Given this list of marker genes RBL1, IKBKE, HIVEP3, LPAR2, SPSB1, DCK, ARID5A, SRSF10, TNKS2, EIF4E, ARHGEF3 (NCBI Gene Id 50650), NEFH, ATF6B, MLLT1, ENTPD4, PRDM2, SH3BP5, HNRNPH3, PTGER4, CHST15, STARD5, MYG1, GATA1, PLEKHA1, AHDC1, RPS26, GTPBP8, WDR77, UBXN11, LTB, SH2B3, TSPAN5, GSAP, PTPN1, CPSF4, KCNIP2, KCNA2, RBM45, RPL4, IDH2, ENDOD1, PUS7L, ARHGEF4, LBH, SLC9A7, ACAD10, IZUMO1R, MEMO1, SIDT1, IL6R, GVINP1, ITM2A, TNIP1, SEMA4B, CORO1B (NCBI Gene Id 57175), SFXN1, INTS7, SMURF2, EHD3, LCK, KLHL3, CYTH3, ARHGAP39, ADAMTS6, IVD (NCBI Gene Id 3712), CRY2, SLC12A7, PFN2, JARID2, B4GALNT4, SLC11A2, TARBP1, REXO2, SH3GL3, PXYLP1, TNFSF8, DZIP1, SMC4, PNISR, TMEM106A, ARHGAP9, RPS10, AFF3, SOX4, ABTB3, SH2D1A, DISP1 (NCBI Gene Id 84976), SEMA6D, IFIT2, SP110, DNAJC7, PGPEP1L, WDR59, THUMPD2, PTGER2, TLR6, SHISA5, TWSG1, MLLT6, TMEM65, RDH5, TCF7, TTC13, SCIN, NF1, PLAGL1, SNAPC3, RNF145, SESN3, SMYD4, LIME1, POLR3E, RIPOR2, RNF43, CES2, SEMA4A, NRARP, TGFBR3, BMP7, AFAP1, MT-ND4L, GPR55, CYP2R1, SIPA1, TMEM192, NXPE3, MRPL58 (NCBI Gene Id 3396), SLC25A35, CSK, PRKCQ, SMARCC1, DTX1, ISOC1, CASD1, SEC61A2, SNTB1, IL17RA, CNDP2, PDK1 (pyruvate dehydrogenase kinase 1), ARHGAP27, FGF13, SCAI, CEP41, TMEM50B, ENTPD5, DKC1, NLK, NT5E, DNAAF5, AGBL5, MPZL3, AIRN, PSMD11, SMAD1, P2RX7, GPR83, MTBP, PARP8, SSBP2, TCF4, PKP4, SLC19A1, LENG8, GRK2, PHF14, MYO3B, CD83, TMCO4, SLC25A40, TNFRSF1A, here is a description of the gene set: Expression profiling of Rag2-deficient Ets1++ and Rag2-deficient Ets1-- mature NK cells and WT bone marrow progenitors, WT T cells, and WT Pro B cells from publication Ramirez K, Chandler KJ, Spaulding C, Zandi S, Sigvardsson M, Graves BJ, Kee BL (PMID 22608498) Genes up-regulated in pro-B cells versus CD4 T cells. Human Gene Set: GSE37301_PRO_BCELL_VS_CD4_TCELL_UP species: Homo sapiens